The following is a description of a gene set: Human Gene Set: GOBP_REGULATION_OF_ACTIVATION_INDUCED_CELL_DEATH_OF_T_CELLS Any process that modulates the occurrence or rate of activation-induced cell death of T cells. studied in species Homo sapiens, and this is the list of marker genes: GPAM, TSC22D3, RIPK3, FADD (Fas associated via death domain), TGFB2